Given this list of marker genes Xrcc5, Slx4, Ercc1, Rtel1, Slx1b, Terf2, here is a description of the gene set: Mouse Gene Set: GOBP_REGULATION_OF_T_CIRCLE_FORMATION Any process that modulates the frequency, rate or extent of t-circle formation. species: Mus musculus